Given this list of marker genes TRPV4, NOTCH2, CUL7, MAN2B1, OBSL1, FGFR3, ITCH, PPP1R15B, CCDC8, ERI1, here is a description of the gene set: Increased top to bottom height of vertebral bodies. Human Gene Set: HP_INCREASED_VERTEBRAL_HEIGHT studied in species Homo sapiens Increased vertebral height